The following is a description of a gene set: studied in species Mus musculus Mouse Gene Set: GOBP_NEURONAL_SIGNAL_TRANSDUCTION The process in which an activated neuronal cell receptor conveys information down a signaling pathway, resulting in a change in the function or state of a cell. This process may be intracellular or intercellular., and this is the list of marker genes: Olfm1, Rtn4r, Clu, Kcna1, Maco1